Given this list of marker genes Dct, Pou3f2, Fgfr2, Pou3f3, Fgfr1, Dixdc1, here is a description of the gene set: The mitotic division of a basal progenitor giving rise to two neurons. Mouse Gene Set: GOBP_FOREBRAIN_VENTRICULAR_ZONE_PROGENITOR_CELL_DIVISION species: Mus musculus